Given this list of marker genes ZBTB24, CCDC39, DNMT3B, SMARCA2, TAP2, CD19, GAS8, NBN, RNU4-2, CFTR, RNF168, GNPTAB, SEC61A1, IL17RA, SCNN1A, SYK, SERPINA1, CR2, IGHG2, ALMS1, CRLF1, DNAJB13, HYDIN, DNAAF5, ODAD3, SLC34A2 (solute carrier family 34 member 2), UBAP2L, FCHO1, CACNA1C, TRAF3IP1, DNAAF11, NFKB2, DNAAF4, RFX7, RPGR, NFKB1, HLA-DQA1, DNAAF1, ZMYND10, SCNN1B, CARMIL2, CCDC65 (NCBI Gene Id 85478, coiled-coil domain containing 65), IRF2BP2, CD79B, TAFAZZIN, TNFRSF13C, SCNN1G (sodium channel epithelial 1 subunit gamma), NOS1, CFAP298, USP26, MS4A1, TNFRSF13B, DNAI1, DNAH7, POLD1, CD79A, TAP1 (NCBI Gene Id 92050), GUSB, ODAD2, EGFR, MAGT1, DPP9, HLA-DQB1, BLM, IGKC, RSPH4A, TNFSF12, CCDC40, SPAG1, MGP, IL2RG, ICOS, CD81, IL10RB, RAC2 (NCBI Gene Id 5880), ICOSLG (inducible T cell costimulator ligand), ATM, DOCK11, here is a description of the gene set: Bronchitis Human Gene Set: HP_BRONCHITIS studied in species Homo sapiens Inflammation of the large airways in the lung including any part of the bronchi from the primary bronchi to the tertiary bronchi.